Given this list of marker genes PRDM4, FZD4-DT, TNFSF8, MCOLN3, PLPBP, DPPA4, FOXN2, IFNG, VWA8-AS1, DKC1, LINC01096, GALNT1, ACE, LACTB2, PPM1A, TNFSF4, CLIC2, TTC16, FBXO10, FKBP7, BRIX1, EPS8, CYP7B1, MYL2, IER3, ATP6V1A, SERPINI2, CDH1, SCRN1, FAM171B, CACNA1A, KPNB1, RAD51C, PLAC4, GSDME, RXYLT1, DNAI4, DEFB125, ZNF492, RSU1, YTHDF1, LINC00648, HORMAD1, ZNF678, GLB1L3, THPO (thrombopoietin), NACA2, AQP8, SERPINF1, TIAM1, ENPP3, GBP1, AMER3, FCGR2A, SLC2A10, HSPH1, ACRBP, IL23R, SFXN2, SDHAF3, CATSPER1, DNM1P46, PPIAL4A, HSP90AA1 (NCBI Gene Id 89272), LATS2, SLC22A2, CUBN, SERINC3, NUP50, CATSPER3, TNFSF14, ZNF99, FANCM, SYPL2, BCAT1, ZPBP2 (zona pellucida binding protein 2), ZC2HC1C, EED, C17orf58, PLRG1, ITGA2B, SLC41A2, MBP, ANK3, STUM, IL12B, MCOLN2, SLC39A9, TEDC2-AS1, ZSWIM5, RAB31, FUT7, DNAJC3, NFATC2, CAPZA1 (NCBI Gene Id 829), CCL22, KBTBD11, RBM4, PIP5K1A, FABP6, APOBEC3A, LRRN3, ADAMDEC1, RAP1A, PLEKHA7, ELAC1, ARMC3, TSPAN2, KLHL23, DGAT2, BTBD10, SRP9, PRKAA2, MYH13, TSPAN9, LTV1, JPH4, AEBP2, B3GALNT2, TEX44, MOCS1, SLC38A7, FICD, CHST2, COL16A1, NLK, IBSP, SRSF7, GCNT4, GARS1-DT, GOLPH3L, PDYN, FAIM, EIF1AX, GLUL, SLC9C2, LINC00667, FAM241A, MREG (NCBI Gene Id 55686), DMRTA1, HSD3B2, ZDHHC2, ZNF572, PURB, NAV1, RDUR, PRO1804, PNLIPRP1, FNDC9, IL1RAP, CCDC168, PAK6-AS1, CPLANE1, ABHD17C, CDKN2A, G3BP1, LINC00529, OPA3, SGO1, H4C8 (NCBI Gene Id 8365), NAA30, WWC2-AS2, SUV39H2, GPR34, UBE4B, YWHAG, FKTN, SPANXC, LINC00630, ADRB2, BRIP1, TNFRSF10A-DT, CYP26B1, NIBAN1, SPEM2, INSYN2A, RGMB (NCBI Gene Id 285705), ULBP3, SLAMF7, TUBB2A, LINC01924, TMEM19, CDH20, NTRK3-AS1, SATB2, ONECUT1, COL12A1, EPRS1, SH3PXD2A-AS1, FBXL21P, RSC1A1, ENC1, BATF3, FXYD7, LINC00698 (long intergenic non-protein coding RNA 698), NOL6, CT45A5, here is a description of the gene set: Genes up-regulated in bone marrow-derived macrophages with STAT6 knockout: control versus treated with IL4. studied in species Homo sapiens Human Gene Set: GSE25088_CTRL_VS_IL4_STIM_STAT6_KO_MACROPHAGE_UP C57Bl/6 wild-type and STAT6 KO mice were used to study PPARg and IL-4 signaling. Bone marrow of 3 mice per group was isolated and differentiated to macrophages with M-CSF (20 ng/ml). 20 ng/ml IL-4 was used to induce alternative macrophage activation and 1 uM Rosiglitazone (RSG) was used to activate PPARg. From each mouse 4 samples were generated: 1. M-CSF, 2. M-CSF+RSG, 3. IL-4 and 4. IL-4+RSG. All compounds were added throughout the whole differentiation process, and frech media was added every other day. Control cells were treated with vehicle (DMSO:ethanol). After 10 days, RNA was isolated and gene expression profiles were analyzed using Mouse Genome 430 2.0 microarrays from Affymetrix. from publication Szanto A, Balint BL, Nagy ZS, Barta E, Dezso B, Pap A, Szeles L, Poliska S, Oros M, Evans RM, Barak Y, Schwabe J, Nagy L (PMID 21093321)